The following is a description of a gene set: Up-regulated genes in the B lymphocyte developmental signature, based on expression profiling of lymphomas from the Emu-myc transgenic mice: the Large Pre-BII stage. from publication Mori S, Rempel RE, Chang JT, Yao G, Lagoo AS, Potti A, Bild A, Nevins JR (PMID 18922927) The Emu-myc transgenic mouse has provided a valuable model for the study of B-cell lymphoma. Making use of gene expression analysis and, in particular, expression signatures of cell signaling pathway activation, we now show that several forms of B lymphoma can be identified in the Emu-myc mice associated with time of tumor onset. Furthermore, one form of Emu-myc tumor with pre-B character is shown to resemble human Burkitt lymphoma, whereas others exhibit more differentiated B-cell characteristics and show similarity with human diffuse large B-cell lymphoma in the pattern of gene expression, as well as oncogenic pathway activation. Importantly, we show that signatures of oncogenic pathway activity provide further dissection of the spectrum of diffuse large B-cell lymphoma, identifying a subset of patients who have very poor prognosis and could benefit from more aggressive or novel therapeutic strategies. Taken together, these studies provide insight into the complexity of the oncogenic process and a novel strategy for dissecting the heterogeneity of B lymphoma. Human Gene Set: MORI_LARGE_PRE_BII_LYMPHOCYTE_UP studied in species Mus musculus, and this is the list of marker genes: CENPA, LGALS1, TUBB, IDE, H2AC8 (H2A clustered histone 8), TUBB4B, MKI67, H2AZ2, TMPO, CENPE, RRM2, HMGB3, RAD21, NUCKS1, MELK, MYBL2, SLC29A1, MCM2, KPNA2, CCNA2, ANAPC5, PSMC1, ALYREF, XRCC6, H2AX, DTL, HNRNPAB, LMNB1, SMARCA4, HMGB1, LGALS9, RAMP1, CDK1, RRM1, LIG1, UBE2S (ubiquitin conjugating enzyme E2 S), ENPEP, MCM3, ZNF358, NCAPH, HMGN2, MCM7, HMGA1, RANGAP1, HJURP, TUBA1A, CDC20, TTK, E2F8, CBX1 (NCBI Gene Id 10951, chromobox 1), CCNB1, PPP2R5C, CDKN3, STMN1, CDCA5, TXN, BUB3, RACGAP1, SLC12A3, CCNB2, FANCC, CENPL, IGLL5, CKS1B, CALM2, MCM6, CMC2, KIF23, AURKA, H2AZ1, SMC2, CDCA3, ASF1B, TOP2A, SLBP, SMC4, RAN, HAUS3, CDKN1A, CDKN2C, RBBP4, CDCA7, KIF22, ANP32E, PRDX4, PRC1 (NCBI Gene Id 9055), SMARCC1